The following is a description of a gene set: Cytokines mediate cell-cell communication in the immune system and represent important therapeutic targets. A myriad of studies have highlighted their central role in immune function, yet we lack a global view of the cellular responses of each immune cell type to each cytokine. To address this gap, the authors created the Immune Dictionary, a compendium of single-cell transcriptomic profiles of more than 17 immune cell types in response to each of 86 cytokines (>1,400 cytokine-cell type combinations) in mouse lymph nodes in vivo. A cytokine-centric view of the dictionary revealed that most cytokines induce highly cell-type-specific responses. For example, the inflammatory cytokine interleukin-1β induces distinct gene programmes in almost every cell type. A cell-type-centric view of the dictionary identified more than 66 cytokine-driven cellular polarization states across immune cell types, including previously uncharacterized states such as an interleukin-18-induced polyfunctional natural killer cell state. Genes negatively differentially expressed in cell type: cDC1 (conventional dendritic cell type 1) upon treatment with cytokine: OSM in mouse lymph nodes in vivo. from publication Cui A, Huang T, Li S, Ma A, Pérez JL, Sander C, Keskin DB, Wu CJ, Fraenkel E, Hacohen N (PMID 38057668) studied in species Mus musculus Mouse Gene Set: CUI_CDC1_OSM_RESPONSE_DN, and this is the list of marker genes: Btg2, Klf2, Jun, Kctd12, Tbc1d4, Arsb, Limd2, Hepacam2, Nedd4, Clk1, Fos, Sec11c, Hspa1a, Nr4a2, Ccr2, H3f3b, Lyz2, Zfp36l1, Cd44, Fosb, Pmaip1, Hspa8, Ckb (NCBI Gene Id 12709)